Given this list of marker genes RGS1, CCL4L2, HAVCR2, HLA-DPB1, CD63, CXCL13, CAPG, GZMB, ALOX5AP, CCL3, ITM2C, HLA-DRB1, ZNF683, PRF1, GNLY, KLRB1, CST7, RGS2, KLRC1, CKLF, RBPJ, ID2, SAMSN1, HLA-DPA1, KLRG1, GZMK, CTSD, LAG3, ITM2A, CD27, GZMH, CCL4, CD7, DUSP2, NKG7, GZMA, CTSW, ITGB2, APOBEC3G, IFNG, LGALS1, TRGC2, CMC1, KLRD1, CXCR6, HOPX, HLA-DRA, DUSP4, TIGIT, here is a description of the gene set: Genes upregulated in subsets of cells of a given type within various tumors Human Gene Set: GAVISH_3CA_METAPROGRAM_CD8_T_CELLS_CYTOTOXIC species: Homo sapiens In this study, an extensive analysis was conducted to define meta-programs (MPs) capturing intra-tumor heterogeneity across a spectrum of tumor types. The approach utilized non-negative matrix factorization (NMF) to analyze each cell type separately within individual tumor samples. This involved the analysis of malignant cells, macrophages, fibroblasts, endothelial cells, epithelial cells, T-cells, and B-cells. NMF was executed with varying parameter values (K=4, 5, 6, 7, 8, 9), thereby generating 39 programs for each cell type per sample. Each NMF program was summarized by the top genes based on NMF coefficients.\nRobust MPs were then delineated for each cell type using a set of stringent criteria, including recurrence within the same tumor, similarity to programs in other tumors, and non-redundancy within a tumor. Subsequently, these robust NMF programs were clustered (per cell type) based on Jaccard similarity, leading to the identification of MPs associated with each cell type.\nTo enhance the quality of the MPs, a refinement steps were undertaken, involving the removal of MPs suspected of reflecting low-quality data (with an overrepresentation of ribosomal proteins or mitochondrial-encoded genes), single-study inclusion, or similarity to miss-annotated cell types. from publication Gavish A, Tyler M, Greenwald AC, Hoefflin R, Simkin D, Tschernichovsky R, Galili Darnell N, Somech E, Barbolin C, Antman T, Kovarsky D, Barrett T, Gonzalez Castro LN, Halder D, Chanoch-Myers R, Laffy J, Mints M, Wider A, Tal R, Spitzer A, Hara T, Raitses-Gurevich M, Stossel C, Golan T, Tirosh A, Suvà ML, Puram SV, Tirosh I (PMID 37258682)